The following is a description of a gene set: Association of TriC/CCT with target proteins during biosynthesis Mouse Gene Set: REACTOME_ASSOCIATION_OF_TRIC_CCT_WITH_TARGET_PROTEINS_DURING_BIOSYNTHESIS studied in species Mus musculus, and this is the list of marker genes: Cct2, Cct8, Cct5 (chaperonin containing TCP1 subunit 5), Cct3 (chaperonin containing TCP1 subunit 3), Cct4, Tcp1, Sphk1, Cct6b, Cct6a, Cct7